The following is a description of a gene set: from publication Chen Y, Wang X (PMID 31504780) species: Homo sapiens Human Gene Set: MIR10395_3P Genes predicted to be targets of miRBase v22 microRNA hsa-miR-10395-3p in miRDB v6.0 with MirTarget v4 prediction scores > 80 (high confidence targets)., and this is the list of marker genes: ZNF554, SPARC, VGLL3, RPRM (reprimo, TP53 dependent G2 arrest mediator homolog), ZEB1 (NCBI Gene Id 6935), CCDC88A, FOXP2, FAM161B, TLL1, ACE, CEACAM5, EBNA1BP2, ZMPSTE24, OXR1, GOLT1B, GPALPP1, RETREG1, HERC4, CUL4B, GTF2A1, HPF1, VPS53 (NCBI Gene Id 55275), ZNF131, TOX, ATXN7, FSBP, QKI, ATP11B, TOB2, IL7, DIP2A (disco interacting protein 2 homolog A), IRF2BP2, C18orf21, CHRNA5, TM7SF3, ZFP1 (NCBI Gene Id 162239), KLF5 (KLF transcription factor 5), YTHDC2, IPO5, KLF6, IGSF10, ZNF704, CEP170, ZNF519, CLGN, ANKS1B, YME1L1, KRTAP4-2, ZNF865, AJUBA, PRDM8, ZNF439, RNF182, SYT10, KLHL42, CETN3, SPIN2A, SLC51A, PLAA, RAB3B, MED13L, PPM1B, MFSD14B, AMER2, CADM2 (NCBI Gene Id 253559, cell adhesion molecule 2), MOB4, TLCD4, SHFL, HNRNPH1, VSIG1, PRND, UQCRB, ANO3, KCTD12, RASGRF1, GTF2B, ODF1, SH3BGRL, PSMD14, MFSD14A, ZNF37A, DNAJC18, RAD54B, KIF13A, CCNG1, OTUD4, HSPE1-MOB4, ZDBF2, MGST1, OPA3, ZNF696, NLRC3, ALDH5A1, ADD3 (NCBI Gene Id 121), PSG5 (NCBI Gene Id 5673), CCDC71L, SNX1, HYCC2, ZHX1, PAXBP1, RABL3, PPP2CA, RPP30, ZCCHC8, TGOLN2, SYPL1, FRY, UGCG, ZNF440, PER1, ZBTB5, ZYG11B, TNKS2, PSG2 (NCBI Gene Id 5670), NLK (NCBI Gene Id 51701), PDE10A, ACBD5 (acyl-CoA binding domain containing 5), FZD6, KCTD6, PARP3, POLR1B, MATR3, PSG11, LRRC1, NMNAT1, EPHX3, NUP58, FHDC1, CD34 (NCBI Gene Id 947), CYP20A1, DSE, DBT, VPS13A, RPF2, GSK3B, NR1H2, KCNT2, WASL, PGM3 (phosphoglucomutase 3), GOLIM4, SFT2D2, ATRNL1